The following is a description of a gene set: Human Gene Set: GOBP_LIPID_HOMEOSTASIS Any process involved in the maintenance of an internal steady state of lipid within an organism or cell. species: Homo sapiens, and this is the list of marker genes: MIR132, HPS6, INSIG1, TLCD2, RTN4, NR1D1, TLCD4, APOA5, MIR27B, MAP2K1, ABCA12, NR1H3 (nuclear receptor subfamily 1 group H member 3), COMMD9, TLCD3B, DGAT1, NR1D2, LIPA, SLC25A27, EHD1, APOA1, CEBPA, IRS2, CLN8, ADORA1, ABHD4, PLA2G12B, MALL, MTLN, SREBF2, LRP5, LIPC, SURF4, HDAC9, ACSM1, COMMD1, MINAR2, ANGPTL4, G6PC1 (glucose-6-phosphatase catalytic subunit 1), NPC1L1, ABCG5, CYP7B1 (NCBI Gene Id 9420), OSBPL11, ZBTB20, SEC24A, MLXIPL, BLOC1S6, NFE2L1, LCAT, ACSM3, MIR379, GPIHBP1, PNLIPRP3, ABCG4, NPC1, PNPLA4, GPAM, ABCG1, RBP1, FUNDC2, ACSM2A, FGFR4, ACACB, ETNPPL (ethanolamine-phosphate phospho-lyase), NR5A2, ABHD5, XBP1, ABCA5, USF1, PNPLA8, LDAH, NR1H2, MIR128-1, USF2, FITM2, ITGB6, PCSK9, C1QTNF3, SESN2, ANGPTL8, TTC39B, ABCA1, LDLR, MALRD1, MED13, ABCB4, HNF4A, OSBPL8, OR10J5, MIR33A, APOA2, PNLIPRP2 (NCBI Gene Id 5408), ORMDL1, MIR182, INS, EPHX2, RCN3, DISP3, PRKAA2, CD24, ADCK1, GRAMD1B, APOC3, TSPO, TLCD3A, LIMA1, ABCD1, ACACA, CNBP, NEGR1, TM6SF2, CERT1 (NCBI Gene Id 10087), PRKAA1, FBXW7, TGFB1, SOAT1, CAV1, TMEM97, MIR148A, MIR33B, APOC4, ABCA3, SCARB1, ABCG8, PNPLA1 (NCBI Gene Id 285848), LAMTOR1, PNLIP, SLC25A46, SIRT1 (sirtuin 1), ORMDL2, ATP13A2, MIR34A, LDLRAP1, THADA, CETP, MIR208A, LPL, DGAT2, ABCB11, CYP7A1, APOM, MIR185, MIR30C1, APOC2, APOC1, LIPG, MYLIP, ABCA2, TLCD1 (NCBI Gene Id 116238), MIR19B1, PLA2G10 (NCBI Gene Id 8399), DDX3X, MTCH2, ABHD8, APOA4, CES1, MIR302A, ANGPTL3, NR1H4, TSKU, MTTP, PNLIPRP1, AKR1C1, MIR590, PNPLA2, ERRFI1, NUS1, RORA, TREM2, ORMDL3, PNPLA3, SAR1B (NCBI Gene Id 56680), GOT1, POLD1, CYP39A1, PPARG, SOAT2, APOB, PLSCR3, GCKR, FABP4, FABP3, HSDL2, RALY, PNPLA5, APOE, ENPP7, RAB30, ACOX1, NPC2, MIR144, AMPD2 (NCBI Gene Id 271), IL18, CAV3